Given this list of marker genes CRIP1, CASS4, PRMT9, SRFBP1 (serum response factor binding protein 1), TBRG1, MCTP1, GTF2H1 (general transcription factor IIH subunit 1), THNSL1, DNAJC6, ZNF704, LAP3, HSPA9, PDS5A, UTP25, RAB33A, PITRM1, SREK1, ELP3, FOSL1, NEAT1, HAUS3, PAPOLA, POLK, PHYKPL, ZWILCH, ERO1A, GMPR, MGLL, FCER1G, ARAP3, CST7, IPO7, SCIN, C7orf25, LUC7L (LUC7 like), C4orf33, HAX1, AUTS2, NBN, C5orf24, BAG4, FER, WNK2, B3GALNT2, STOML2, DHRS3, TNFAIP1, QNG1, CIPC, EML1, SHQ1, NFU1, EIF1AY, TRAP1, TGM1 (transglutaminase 1), CLN8, RPS19BP1, VPS50, HSBP1, ARHGDIG, TRMT112, NCF4, CIAO1, NRXN2, WNT10A, PTK2, XRCC5, GTF2E2, TEC, TUBB3, CXCR5, CBR1, PNPT1, HOPX, CFDP1, C3orf80, DCAF12L1, PGAM1, TRIM42, ANKRD42, SLC2A1, SLC12A7, SLC45A3, GPR89B, FAM210A, HILPDA, ICE2, EPS8L2, PSMG1, IER2, HK2, EPHX1 (NCBI Gene Id 2052), AMZ1, TRIP6, THY1, CA2, PHAX, HEATR3, TNFRSF19, RNF149, RSL1D1, FAM120A, DDC (dopa decarboxylase), RPP14 (ribonuclease P/MRP subunit p14), PUS7, CTDSPL, ZNF768, CD72, TSPAN4, BAG2, SLC7A7, PTPN22, DHX37, ZNF839, TMEM40, EMP2, CD244, NEFH, NAA20, LMAN2L, LDLRAD4, PSMD7, MMP14, MEX3A, ENDOD1, ESF1, NDRG1, CD9, SHCBP1L, GTF2I, CNN1, SPRY2, LGI2, MSRB2, CYP11A1, FBL, PRELID2, INTS2, GNPNAT1, RFTN2, RANBP1, OVGP1, LCK, CISH (cytokine inducible SH2 containing protein), DAB2IP, TIMM21, TOP1MT, ZAN, PICK1, SCN4B, NUDT2, HPGD, ANKRD33B, SLC25A37, FETUB, PELP1, TMEM181, ELP2, PPP1R26, HINT1, HBEGF, GOLGA1, CHRNB1, EXOSC1, SLTM, EPCAM, ID3, ANKRD26, ATAD2, MAT2A, TNP1, CMTM8, ELFN1, GOLM1, MRPL24, NAF1, TBCK, MFSD13A, HIRIP3, GTF2IRD1, KIF13A, CRACDL, AZI2, PARL (presenilin associated rhomboid like), RINT1, POLR1A, PLA2G15, EIF4A2, CEP170B, KRT20, STX1A (syntaxin 1A), ELL3, DKKL1, SESTD1, MRPS22, TMEM41A, SLC6A6, here is a description of the gene set: Genes up-regulated in livers injected with IL6: SOCS3 knockout versus wildtype. from publication Croker BA, Krebs DL, Zhang JG, Wormald S, Willson TA, Stanley EG, Robb L, Greenhalgh CJ, Förster I, Clausen BE, Nicola NA, Metcalf D, Hilton DJ, Roberts AW, Alexander WS (PMID 12754505) Changes in mouse liver mRNA profiles following intraperitoneal cytokine injection. Either interferon-gamma-/-, albumin-cre(-) Socs3(w/fl) mice, or albumin-cre(+) Socs3(-/fl) mice were injected with either phosphate-buffered saline, interferon-gamma, or interfeukin-6, and livers taken after 4h. Human Gene Set: GSE369_SOCS3_KO_VS_WT_LIVER_POST_IL6_INJECTION_UP studied in species Homo sapiens